The following is a description of a gene set: Any process that modulates the physical form of a postsynapse. Human Gene Set: GOBP_REGULATION_OF_POSTSYNAPSE_ORGANIZATION species: Homo sapiens, and this is the list of marker genes: ABI3, PPP1R9B, LRRK2, ARHGAP44, PTPRS, LZTS1, GRIN2B, DOCK4, ARC, PPFIA2, CAMK2B, TRIM47, CUX2, EPHB2, RAC3, CFL1, NF1, ADAM10, SHANK3, CASKIN1, PDLIM5, ITPKA, CHMP2B, ARHGEF15, ZMYND8, RHOG, CDKL5, CDC42, NEDD9, ASIC1, TANC2, FYN, PSEN1 (presenilin 1), IL1RAP, SLC12A5, GRID1, ITSN1, APP, ARMCX5-GPRASP2, NRP2, LRP4, CAPRIN2, CRIPT, PRICKLE1, ZNF804A, LRFN1, FCGR2B, DVL1, CC2D1A, DISC1, LRRC4B, RPS6KA5, CARMIL3, ZDHHC8, DTNBP1, BAIAP2 (BAR/IMD domain containing adaptor protein 2), ASIC2, ABHD17A, PAFAH1B1, LRFN2, LZTS3, CDK5, NCKIPSD, CRMP1, MAP1B, UBE3B (NCBI Gene Id 89910), CDK5R1, STAU2, SIGMAR1, PAK3, CBLN1, SYNDIG1, ZDHHC15, KIF1A, SLC30A1, PLPPR4, RELN, LRFN4, DHX36, DOCK10, CYFIP2, ARF4, NGEF, APOE, LRRTM2, PTPRD, CDH2, SRCIN1, PRNP, PTK2B, NAE1, LRP8, SENP1, GHSR, ABHD17C (NCBI Gene Id 58489), EPHA4, HOMER1, EEF2K, CAPRIN1, PUM2, NEURL1, DOCK1, NECTIN3, EFNA1, IL1RAPL1, ARHGAP33 (NCBI Gene Id 93092), ELMO1, ABHD17B, MIR30B, SEMA4C, RTN4R, GNA13, SIPA1L1, HTR4, RTN4, WNT7A, FGFR1, INS, VPS35, LILRB2, WNT5A, SEMA3F, ARHGAP12, NLGN1, TANC1, RAC1, GHRL, MARK1, NRCAM, GRID2, NUMBL, S1PR2, ABI2, AKT1 (AKT serine/threonine kinase 1), WASL, GPRASP3, DBN1, ARHGAP22, EPHA7, NEDD8 (NCBI Gene Id 82917), UBE2M, LATS1, NRXN2, PTPN1